Given this list of marker genes PIK3CA, AKT3, PIK3CD, PIK3CB, EGF, AKT1, EGFR, AKT2, here is a description of the gene set: EGF-overexpression to PI3K signaling pathway. Pathway ID: N00281. Pathway type: Variant. Pathway class: nt06260 Colorectal cancer. Pathway Definition from KEGG: EGF* -> EGFR -> PI3K -> PIP3 -> AKT species: Homo sapiens Human Gene Set: KEGG_MEDICUS_VARIANT_EGF_OVEREXPRESSION_TO_PI3K_SIGNALING_PATHWAY